The following is a description of a gene set: Human Gene Set: GOBP_SYNAPTIC_MEMBRANE_ADHESION The attachment of presynaptic membrane to postsynaptic membrane via adhesion molecules that are at least partially embedded in the plasma membrane. studied in species Homo sapiens, and this is the list of marker genes: LRFN4, CDH10, SLITRK5, TENM4, FLRT3, SLITRK1, LRFN3, GPC4, IL1RAP, EFNA5, NTNG2, CDH9, PTPRF, PCDH8, ITGA3, SPARCL1, PTPRS, LRRC4C, ELFN2, MDGA1, LRFN5, CDH6, SLITRK3, IL1RAPL1, LRRC4B, ELFN1, NTNG1, PTPRD, MAPK14, LRRC4, SLITRK2, PCDH17